The following is a description of a gene set: studied in species Homo sapiens Human Gene Set: GOBP_SIALYLATION The covalent attachment of sialic acid to a substrate molecule., and this is the list of marker genes: ST3GAL2, ST6GAL2, ST8SIA3, ST8SIA2, ST6GAL1, ST8SIA4, C20orf173, ST6GALNAC2, ST3GAL1, ST3GAL4